The following is a description of a gene set: Mouse Gene Set: GOCC_DOPAMINERGIC_SYNAPSE studied in species Mus musculus A synapse that uses dopamine as a neurotransmitter., and this is the list of marker genes: Septin4, Adra2a (NCBI Gene Id 11551), Atg7, Flot1, Syt11, Slc10a4, Adra1a, Chrna5, Chrnb3, Sv2c, Slc6a3, Vps35, Drd2, Slc18a2, Chrna3, Rab3b, Nlgn2, Prkn, Drd3, Chrna6, Chrna4, Chrnb2